Given this list of marker genes Patj, Pfkfb3, Srsf1 (NCBI Gene Id 70724), Zmym4, Ebf1, Zeb1, Picalm, Tmem121b, Erv3, Shpk, Msl1, Dstyk, Atg2a, Gm6040, Neurog2, Ndc1, Stmn1, Wnt3a (wingless-type MMTV integration site family, member 3A), Mex3a, Mrpl1, Zfp831, Tnrc6b, Emp1, Zfp426 (NCBI Gene Id 72998), Ubash3b, Tk2, Cc2d1b, Crispld2, Soat1, Otud7b, Cenpa, Scn8a, Tfap2a, Slc25a19, Syncrip, Mapk14, Eeig1, Thra, Rhbdl3, Ifit3, Zfp748, Trpm8, Fam228a, St3gal3, Nhlh2 (NCBI Gene Id 320182), Kdm7a, Zdhhc17, Armh3, Crim1 (NCBI Gene Id 50766), Acvr2a, Zfp965, Lrch3, Cemip, Qrfp, Chst11, Dlg3, Lpgat1, Gal3st1, Acss1, Grpel2, Scn2b, Cdk14, Gm12886, Armcx3, Adgrl2, Arxes2, Agap1, Ivns1abp, Grik5, Gdap1, Gpnmb, Serpine1, Slc5a10, Raph1, Zfp973, Lyrm9, Fam167b, Zfp458, Spryd4, Saa4, Cdh19, Csf1r, Inpp5a, here is a description of the gene set: Mouse Gene Set: MIR_1894_5P studied in species Mus musculus from publication Chen Y, Wang X (PMID 31504780) Genes predicted to be targets of miRBase v22 microRNA mmu_miR_1894_5p in miRDB v6.0 with MirTarget v4 prediction scores > 80 (high confidence targets).